The following is a description of a gene set: Human Gene Set: GOMF_2_ACYLGLYCEROL_3_PHOSPHATE_O_ACYLTRANSFERASE_ACTIVITY species: Homo sapiens Catalysis of the reaction: 2-acyl-sn-glycerol 3-phosphate + acyl-CoA = L-phosphatidate + CoA., and this is the list of marker genes: MBOAT2, MBOAT1, LPCAT1, MBOAT7, LPGAT1, LPCAT3, CRLS1, LPCAT2, LPCAT4